Given this list of marker genes Cfl1, Hrg (histidine-rich glycoprotein), Coro1b, Plxnb3 (plexin B3), Slit2, Kank1, Arpin, Abi3, here is a description of the gene set: Any process that stops, prevents or reduces the frequency, rate or extent of lamellipodium organization. Mouse Gene Set: GOBP_NEGATIVE_REGULATION_OF_LAMELLIPODIUM_ORGANIZATION species: Mus musculus